The following is a description of a gene set: Human Gene Set: ZHAN_MULTIPLE_MYELOMA_DN studied in species Homo sapiens from publication Zhan F, Hardin J, Kordsmeier B, Bumm K, Zheng M, Tian E, Sanderson R, Yang Y, Wilson C, Zangari M, Anaissie E, Morris C, Muwalla F, van Rhee F, Fassas A, Crowley J, Tricot G, Barlogie B, Shaughnessy J Jr (PMID 11861292) Bone marrow plasma cells (PCs) from 74 patients with newly diagnosed multiple myeloma (MM), 5 with monoclonal gammopathy of undetermined significance (MGUS), and 31 healthy volunteers (normal PCs) were purified by CD138(+) selection. Gene expression of purified PCs and 7 MM cell lines were profiled using high-density oligonucleotide microarrays interrogating about genes. On hierarchical clustering analysis, normal and MM PCs were differentiated and 4 distinct subgroups of MM (MM1, MM2, MM3, and MM4) were identified. The expression pattern of MM1 was similar to normal PCs and MGUS, whereas MM4 was similar to MM cell lines. Clinical parameters linked to poor prognosis, abnormal karyotype (P =.002) and high serum beta(2)-microglobulin levels (P =.0005), were most prevalent in MM4. Also, genes involved in DNA metabolism and cell cycle control were overexpressed in a comparison of MM1 and MM4. In addition, using chi(2) and Wilcoxon rank sum tests, 120 novel candidate disease genes were identified that discriminate normal and malignant PCs (P <.0001); many are involved in adhesion, apoptosis, cell cycle, drug resistance, growth arrest, oncogenesis, signaling, and transcription. A total of genes, including FGFR3 and CCND1, exhibited highly elevated (spiked) expression in at least 4 of the 74 MM cases (range, 4-25 spikes). Elevated expression of these genes was caused by the translocation t(4;14)(p16;q32) or t(11;14)(q13;q32). Thus, novel candidate MM disease genes have been identified using gene expression profiling and this profiling has led to the development of a gene-based classification system for MM. Genes most significantly down-regulated in multiple myeloma samples, compared to normal bone marrow plasma cells., and this is the list of marker genes: ELANE, MRC1, CD72, VCAM1, SYK, GP5, CTSH, S100A9, HHEX, DPYSL2, ITGB2, ITGA2B, SMPDL3A, WNT10B, PLA2G7, PYGL, LYZ, APOC1, GLDC, CD27, A2M, ALDH1A1, CD24, CXCL12, COL1A2, PF4V1, RNASE6, LIPA, TCF7, DEFA1, IGF2BP3, LCN2, APOE, PRKAR2B, PF4, S100A12, MSX1, LST1 (leukocyte specific transcript 1), HNMT, CEBPD, CD99, AIF1